The following is a description of a gene set: Human Gene Set: HP_POSTERIOR_PLAGIOCEPHALY Asymmetry of the posterior part of the skull. Posterior plagiocephaly species: Homo sapiens, and this is the list of marker genes: ADNP (activity dependent neuroprotector homeobox), CACNA2D1, CDC42BPB, RFX7, GRIA1, ALG12, CAMK2A